Given this list of marker genes TSPAN12, ATOH7, KIF11, PRSS56, NDP, CTNNB1, PIEZO2, ZNF408, TUBGCP6, LRP5, FZD4, here is a description of the gene set: A wrinkle of retinal tissue projecting outward from the surface of the retina and visible as a line on fundoscopy. species: Homo sapiens Retinal fold Human Gene Set: HP_RETINAL_FOLD